Given this list of marker genes DRD1, DLG4, PPT1, SLC1A1, APRT, SLITRK5, NMUR2, CNTNAP4, AVPR1A, DDO, NMU, OXT, HOXB8, DRD2, QRFP, AVP, HPRT1, CTNS, here is a description of the gene set: Human Gene Set: GOBP_GROOMING_BEHAVIOR species: Homo sapiens The specific behavior of an organism relating to grooming, cleaning and brushing to remove dirt and parasites.